The following is a description of a gene set: Human Gene Set: WOTTON_RUNX_TARGETS_UP species: Mus musculus from publication Wotton S, Terry A, Kilbey A, Jenkins A, Herzyk P, Cameron E, Neil JC (PMID 18560354) The Runx genes are important in development and cancer, where they can act either as oncogenes or tumour suppressors. We compared the effects of ectopic Runx expression in established fibroblasts, where all three genes produce an indistinguishable phenotype entailing epithelioid morphology and increased cell survival under stress conditions. Gene array analysis revealed a strongly overlapping transcriptional signature, with no examples of opposing regulation of the same target gene. A common set of 50 highly regulated genes was identified after further filtering on regulation by inducible RUNX1-ER. This set revealed a strong bias toward genes with annotated roles in cancer and development, and a preponderance of targets encoding extracellular or surface proteins, reflecting the marked effects of Runx on cell adhesion. Furthermore, in silico prediction of resistance to glucocorticoid growth inhibition was confirmed in fibroblasts and lymphoid cells expressing ectopic Runx. The effects of fibroblast expression of common RUNX1 fusion oncoproteins (RUNX1-ETO, TEL-RUNX1 and CBFB-MYH11) were also tested. Although two direct Runx activation target genes were repressed (Ncam1 and Rgc32), the fusion proteins appeared to disrupt the regulation of downregulated targets (Cebpd, Id2 and Rgs2) rather than impose constitutive repression. These results elucidate the oncogenic potential of the Runx family and reveal novel targets for therapeutic inhibition. Common target genes up-regulated by all three Runx family members (RUNX1, RUNX2, and RUNX3) in MEF cells (embryonic fibroblasts)., and this is the list of marker genes: CCL2, GPR15LG, RDH10, SERTAD4, KHK, SLC40A1, UGCG, LY6E, NCAM1, CDK18, CCL7, CYP1B1, TIMP4, ST3GAL5, ITGB5, MASP1, TMEM268, RNF19B, WWP2, RGCC, ANGPTL4